Given this list of marker genes UBE2A, TTC7A, GJB2, FCN3, GJB6, AP3B1, PSEN1, STAT3, CD3D, BTK, CD3E, SYK (NCBI Gene Id 6850), CARMIL2 (capping protein regulator and myosin 1 linker 2), LCP2, NCF2, CEBPE, PSENEN, CD247, PI4KA, CTSC, SEC61A1, SP110, here is a description of the gene set: Recurrent abscess formation species: Homo sapiens An increased susceptibility to abscess formation, as manifested by a medical history of recurrent abscesses. Human Gene Set: HP_RECURRENT_ABSCESS_FORMATION